Given this list of marker genes Fos, Mapk9, Psma2, Pdpk1, Pik3r2, Ubb, Psma4, Map2k7, Psma3, Tec (tec protein tyrosine kinase), Plcg2, Nfkbia, Itk, Cul1, Ikbkb, Ube2n, Psmd6, Psmb5, Vav1, Psmd12, Psmd13, Malt1, Psmb6, Psmc6, Ppp3r1, Ube2d1, Psma5, Psmd1, Ube2v1, Psma7, Grb2, Mapk3, Mapk8, Psmc1, Psma1, Ms4a2, Map2k4, Lcp2, Psma6, Psmc2, Psmc4, Igll1, Shc1, Psmb7, Syk, Pik3cb, Lat, Psmd7, Tab3, Calm1, Fcer1a, Tab2, Psmb4, Cdc34, Rps27a, Nfkb1, Jun, Psmc3, Tab1, Grap2, Rela, Hras, Psmc5, here is a description of the gene set: Reactome Pathway: Fc epsilon receptor (FCERI) signaling This event has been computationally inferred from an event that has been demonstrated in another species.<p>The inference is based on the homology mapping from PANTHER. Briefly, reactions for which all involved PhysicalEntities (in input, output and catalyst) have a mapped orthologue/paralogue (for complexes at least 75% of components must have a mapping) are inferred to the other species. species: Mus musculus part of: Innate Immune System electronically inferred by orthology from the curated human pathway